The following is a description of a gene set: Genes predicted to be targets of miRBase v22 microRNA mmu_miR_3075_3p in miRDB v6.0 with MirTarget v4 prediction scores > 80 (high confidence targets). Mouse Gene Set: MIR_3075_3P from publication Chen Y, Wang X (PMID 31504780) studied in species Mus musculus, and this is the list of marker genes: Zfp263, Ttll9, Xxylt1, Sycp1, Ccn4, Rph3a, Chm, Prr23a4, Ahcyl2, Metap2, Ppp3ca, Tafa1, Setbp1, Ano6, Hnrnpul2, Celf4, Adgrl4, Rassf3, Dcx, Dapp1, Mex3c, Arel1, Dapk1, Srgap3, Chtf8, 2010106E10Rik, Eps8l2, Lmtk2, Pafah1b2, Hic2, Nav1, Rce1, Car12, Zfp518a, Pdlim5, Btg1, Dpyd, Mroh5, Dclre1b, Fam91a1, Arhgef15, Gm527, Tgfbr2, Dmd, Mga, Ccdc117, Plekhg4, Myt1l, Trpc5, Ophn1 (oligophrenin 1), Muc15, Lrp8, Nr2f2, Ccdc142, Bach2, Cdk6, Filip1l, Arf4, Fnip1, Cbln2, Sepsecs (NCBI Gene Id 52242), Myct1, Tle4, Evx2, Zfp280c, Atoh8, Rbmxl2, Gprc5b, Tspan31, Rapgef6, Slc9a9, Npepps, Rad18, Dnajc16, Fdft1, Tafa2, Slc7a14, Sh3rf2, Srd5a1, Nfyc, Ak2, Pianp, Hpn, Clic4, Sertad4, Smim10l1, Slc12a6, Eml4, Smcr8, Cuedc2, Zfp189, Dll1, Gpr15, Ormdl1